The following is a description of a gene set: Difficulty in swallowing. Dysphagia species: Homo sapiens Human Gene Set: HP_DYSPHAGIA, and this is the list of marker genes: CTNS, PRPH, MADD, NKX2-5, TOR1A, GNB1, SLC6A9, VPS13A, RELN (NCBI Gene Id 5649), GPRC5B, MACF1, CAV1, MYOT, TGM6, CHMP1A, CCR6, CHD7, FBXL4, KAT6B, CHRND, GRM1, MT-ND4, HPCA (NCBI Gene Id 3208), PLEC, EXOSC9, DTYMK, FGFR2, ATP7A, ATP2B3, GNS, ASAH1, CFAP410, MAN2C1, STXBP1, ATP5F1A, POLG, POLG2, SLC32A1, EXOSC5, PFN1, HNRNPA1, ADD3, PAX8, DMPK, ACOX1, TTBK2, MYH2, GRHL2, LAMB2, ITGA7, TYMS, CLCN1, SCN2A, NR4A2, KCNK9, ADAR, ATG7, PRKCG, TPM2, NOTCH3 (NCBI Gene Id 791), UBQLN2, MPZ (myelin protein zero), ACTA1, DNAJB6, ATP1A3, IDH2, GFAP, SLC25A1, PANK2, SIGMAR1, MSX1, PDPN, UBTF (NCBI Gene Id 7343), FLCN, MED17 (NCBI Gene Id 9440), CYP7B1, RHBDF2, TARDBP, SCN1B, MUSK, PLP1, EIF4A2, MRPS28, SOD1, SNAP25, GNAQ, STIL, GSN, MTHFS, ATXN2, FGF10, PRNP, CASZ1, SYT14, NF1, SOX9, NUS1, MECR, HPDL, KIT, KCNAB2, CDC73, FA2H, ZEB2, WASHC5, NUP54, KMT2B, PLA2G6, SNCA, COL7A1, SNF8, ATP1A2, EXT2, COQ4, DAO, VAC14, TP63, LRPPRC, MTRFR, CACNA1A, CCNF, KIF5A, TBP, PRDX3, KY, SPG11, HLA-B (NCBI Gene Id 730410), PYROXD1, GCDH, MYH11, UNC45B, VAPB, HTRA1, CDON, AGRN, CHRNE, SNCAIP, FRG1, PDE8B, OCA2, XRCC1, LRRK2, KCND3, GABRD, ADNP, MATR3, LMX1B, KCNC3, HPRT1, EXT1, HMGCR, FKRP, VARS1, UBE4B, HLA-DRB1, GLB1 (galactosidase beta 1), TNNT1, ANXA11, CAD, MGME1, SON, GBA1, SATB1, GRHL3, TPM3, MT-ND2, FGFR3, IKZF1, ASCC3, NDUFA9, COL4A6 (collagen type IV alpha 6 chain), ZMYM2, COLQ, IL6ST, HTRA2, CDKL5, ALDH4A1, DDHD2, PTCH1, HLA-DQB1, TFG, PON2, NAA10, CAPRIN1, PLIN4, COQ2, SDHB (succinate dehydrogenase complex iron sulfur subunit B), WAC, EIF4G1, DGUOK, SLC12A2 (solute carrier family 12 member 2), PIGP, SQSTM1, MEGF10, FMR1, SLC52A2, FXN, PNKD, RAI1, IRF6, TUBB4A, PRPS1, DCTN1, RRM2B, CHCHD10, TRIM8, DNAJC13, AMPD2, FGF8, PCNA, PUS3, POLR3A, CRLF1, GALC, NDUFA6, UNC13A, EIF5A, SPART, ERBB4, PIK3R5, ALDH18A1, TSEN15, TANGO2, SRPX2, MT-TL1, SDHC, RIC1, TRIP4, HLA-DQA1, VPS11, REEP1, IPO8, TIMM8A, PMP22, MT-ND6, GRM7, HEPACAM, TBK1, CAVIN1, CEP85L, DAB1, FIG4, SETX, SYT2, NDUFS3, ZC4H2, AR, GJB1, ENSG00000288330, PRDM13, STAG2, TNPO3, HSD17B10, LIFR (NCBI Gene Id 3977), NOP56, PIGA, SLC18A3, SATB2, DLX4, HOXB1, SPG21, NEB (nebulin), DNM1L, DLL1, PPARGC1A, NTRK1, ATXN1, AFG3L2, STUB1, CYP27A1, SEMA3E, RRM1, POLR3B, NGLY1, MYH14, TTC19, FLAD1, DKK1, EBF3, GRIN1, LIG3, POLR1A, KBTBD13, ABCD1, NSRP1, QDPR, MT-TV, SKI, GRIN2D, MT-TT, OPA1, MMP1, ATXN7, B4GALNT1, NOS1, FGFR1, PABPN1, MT-TW, TSEN2, RILPL1, PEX1, SACS, SCUBE3 (signal peptide, CUB domain and EGF like domain containing 3), EPRS1, LAMA2, EPG5, BRAF, OPTN, APP, MRPS25, GLT8D1, MYMK, TK2, SYNJ1, HTT, SPTBN4, TRIO, IRF2BPL, ATP7B, SETBP1, COBLL1, CDH1, CACNA1G, CRYAB, CTNNB1, HMBS, MT-ND1, DPYSL5, KLHL40, WARS2, FTH1, RLIM, ASCC1, TUBB6, SCARB2, PRDM16, CARS2, KLHL7, UBE3A, PLAA, ATXN10, CARMIL2, DDC, VRK1, ECM1, PON1, ACTB, CHRNA1, ZNF699, PRKRA, SLC25A4, TYMP, REV3L, CRIPTO, GFPT1, GOSR2, NOTCH2NLC, NDUFS1, AOPEP, GAS1, DES, CNBP (NCBI Gene Id 7555), LBR, MYO9A, VCP, MT-ATP6, IDH1, TWNK, UCHL1, GLI2, REPS1, PTS, SDHD (succinate dehydrogenase complex subunit D), SLC44A1, HACD1, KMT2A, HSPG2, DISP1, TRAPPC12, GLE1, MPV17, FERMT1, GDAP2 (ganglioside induced differentiation associated protein 2), CLN8, LONP1, KCNA1, SPG7, SLC25A22, SPEN, YARS2, TAMM41, PLXND1, ATXN8OS, PUF60, STAT3, SEC31A, GMPPA, CNTNAP1, NDE1, PTRHD1, APOE, TGIF1, NEK1, FTL, COL13A1, PIGQ, VPS13C, FUS, MYO1H, UBB, TSEN34, JAG1, YY1, SLC1A4, VAMP1 (vesicle associated membrane protein 1), ADH1C, SLC5A7, CHAT, NPC1, FBXO7, SCN3A, PNKP, DYSF, VPS35, TAF1, SLC52A3, NCAPG2, ARHGEF38, NUP62, ANKRD11, GIGYF2, PDP1, SLC1A3, MID1, PSAP, NECTIN1 (nectin cell adhesion molecule 1), TRAPPC6B, KIAA0319L, DLG1 (NCBI Gene Id 1739, discs large MAGUK scaffold protein 1), ARX, RNF170, TBC1D23, GCH1, RERE, NPC2, NEUROD2, CACNA1C, ITPR1, PAX7, KLHL41, KAT6A, ALS2, ATN1, ZIC2, MT-TK, HEXB, MYORG, ADCY6, RNU4-2, ZFYVE26, HNRNPA2B1, SEPSECS, CASK, LUZP1, PLCH1, NAA60, NEFL, PIGN, MAPT, MAP2K2, IRF5, TPP1 (NCBI Gene Id 727719), MYL2, NUTM2B-AS1 (NUTM2B antisense RNA 1), SDHA, ARHGAP29, FLNC, LRP12, MFF, CHMP2B, DMXL2, GBA2, PI4KA, MT-ND5, TBCD, HGSNAT, MB, MT-ND3, DCX, SPTSSA, TSEN54, TREM2, MYPN, CSPP1 (centrosome and spindle pole associated protein 1), NEU1, NDUFAF2, ACTG2, PON3, SERPING1, MECP2, MINPP1, BMP4, GIPC1, SLC2A3, RNASEH1, FOXP2, LMNB1, FOXH1, SELENON, MYH8, SRD5A3, GNAO1, AASS, MT-ATP8, PRKCZ, ANG, RARS1, TOP3A, PDGFRA, ATXN3, BAP1, GNB2, TAF15, ADGRG1, FARS2, SPTLC1, SMC1A (NCBI Gene Id 8243), LMOD3, FBXO28, ASPA, AHDC1, PYGM, COL4A5, ZFX, PEX16, NEFH, WFS1, NF2, MAP3K20, MRPS34, GEMIN4 (gem nuclear organelle associated protein 4), SCN4A, DYRK1A, ERLIN2, CSF1R, MMP23B, SHH, NODAL, SIX3, GUCY1A1, ATP13A2, PSEN1, CCN2, SLC19A3, PHEX, SLC9A6, KATNB1, AQP4, NONO, SIK1